Given this list of marker genes TRIM14 (tripartite motif containing 14), MMP7, SGPL1, PYCARD, STAT1, MX1, CXCL5, IFITM1 (interferon induced transmembrane protein 1), TACSTD2, CCND1, MDM2, BCL2L1, MET, IFNB1, GRN, TSPAN5, RAD21, LEF1-AS1, DDX11, IFI44, EGFR, BST2, CGB3, IGFBP4, GAS2L1, CD44, here is a description of the gene set: Cellular proliferation, growth, apoptosis and Wnt signaling genes down-regulated in SNU638 cells (gastric cancer) by overexpression of SFRP2 off a plasmid vector. Human Gene Set: NOJIMA_SFRP2_TARGETS_DN studied in species Homo sapiens from publication Nojima M, Suzuki H, Toyota M, Watanabe Y, Maruyama R, Sasaki S, Sasaki Y, Mita H, Nishikawa N, Yamaguchi K, Hirata K, Itoh F, Tokino T, Mori M, Imai K, Shinomura Y (PMID 17297461) Activation of Wnt signaling has been implicated in gastric tumorigenesis, although mutations in APC (adenomatous polyposis coli), CTNNB1 (beta-catenin) and AXIN are seen much less frequently in gastric cancer (GC) than in colorectal cancer. In the present study, we investigated the relationship between activation of Wnt signaling and changes in the expression of secreted frizzled-related protein (SFRP) family genes in GC. We frequently observed nuclear beta-catenin accumulation (13/15; 87%) and detected the active form of beta-catenin in most (12/16; 75%) GC cell lines. CpG methylation-dependent silencing of SFRP1, SFRP2 and SFRP5 was frequently seen among GC cell lines (SFRP1, 16/16, 100%; SFRP2, 16/16, 100%; SFRP5, 13/16, 81%) and primary GC specimens (SFRP1, 42/46, 91%; SFRP2, 44/46, 96%; SFRP5, 30/46, 65%), and treatment with the DNA methyltransferase inhibitor 5-aza-2'-deoxycytidine rapidly restored SFRP expression. Ectopic expression of SFRPs downregulated T-cell factor/lymphocyte enhancer factor transcriptional activity, suppressed cell growth and induced apoptosis in GC cells. Analysis of global expression revealed that overexpression of SFRP2 repressed Wnt target genes and induced changes in the expression of numerous genes related to proliferation, growth and apoptosis in GC cells. It thus appears that aberrant SFRP methylation is one of the major mechanisms by which Wnt signaling is activated in GC.